The following is a description of a gene set: species: Mus musculus Mouse Gene Set: GOBP_GASTRIC_ACID_SECRETION The regulated release of gastric acid (hydrochloric acid) by parietal or oxyntic cells during digestion., and this is the list of marker genes: Slc26a7 (solute carrier family 26, member 7), Gpr39, Hrh2, Hip1r, Tff2, Cckar, Ghrl, Chrm5, Snx10, Ptger3, Kcnq1, Sct, Nmu, Cckbr, Slc9a4